Given this list of marker genes HEY2, ANTXR1, FBN1, LIPC, PRKG1, WRN, LCAT, LDLR (low density lipoprotein receptor), ASAH1, MAT2A, SMAD2, ZMPSTE24, SMARCAL1, PNPLA2, ERCC5, NPC2, HLA-DRB1, LRP6, XYLT1, APOE, TGFBR2, TNXB, COL3A1, TGFB2, NPC1, THSD1, PPARG, ERCC8 (NCBI Gene Id 2075), LPL, PCSK9, ENG, CYP7A1, TGFBR1, GPIHBP1, LOX, CSF2RB (colony stimulating factor 2 receptor subunit beta), ABCG8, ERCC6, CEP19, EPHX2, ERCC4, ELN, ERCC3, FOXE3, ABCA1, ACTA2, GHR, APOA1, THSD4 (thrombospondin type 1 domain containing 4), GGCX, SMPD1, LDLRAP1, BANF1, CYP27A1 (cytochrome P450 family 27 subfamily A member 1), TGFB3, APOB, CELA2A, MFAP5, ALMS1, CSF2RA, HGD, ESR1, SC5D, PIK3CG, SMAD3, APOA5, APOA2, LAMB2, PPP1R17, XYLT2, HTRA1, MYH11, ABCC6, SERPIND1, LIPA, MEF2A, ANGPTL6, SMAD4, NEU1, AGXT, TGFBR3, MYLK, BRCC3, CAT, ZNF687, GLB1, ERCC2, LMNA, ABCG5, here is a description of the gene set: studied in species Homo sapiens Arteriosclerosis Sclerosis (hardening) of the arteries with increased thickness of the wall of arteries as well as increased stiffness and a loss of elasticity. Human Gene Set: HP_ARTERIOSCLEROSIS